The following is a description of a gene set: studied in species Homo sapiens Human Gene Set: WP_ATM_SIGNALING ATM signaling, and this is the list of marker genes: CHEK2, MAPK9 (NCBI Gene Id 5601), TP73, H2AX, CHEK1, CREB1, BID, RAD9A, CASP2, CDC25A, CDK2, TLK1, MDC1, SMC1A, TP53BP1, RAD51, BRCA1, CDKN1A, CCNE1, MDM4, RAD50, GADD45A (growth arrest and DNA damage inducible alpha), NBN, ATF2, ATM (ATM serine/threonine kinase), TP53, IKBKG, CRADD, RIPK1, MDM2, PIDD1, MRE11, CCNB1, CDC25C (NCBI Gene Id 995), JUN, ABL1, CDK1